Given this list of marker genes Fmo1, Acacb, Fmo4, Mir214, Appl2, Dbi, Mir199a-2, Fmo2, Akt1, Acadl, Plin5, Etfbkmt, Acadvl, Mfsd2a, Sox9, Cnr1, Dgat2, Sirt4, here is a description of the gene set: species: Mus musculus Any process that stops, prevents, or reduces the frequency, rate or extent of fatty acid oxidation. Mouse Gene Set: GOBP_NEGATIVE_REGULATION_OF_FATTY_ACID_OXIDATION